Given this list of marker genes IMPG1, CFAP410, TTLL5, CABP4, GNB3, RD3, CACNA1F, GDF6, TOPORS, PDE6H, TULP1, IFT140, ATF6, LRAT, IFT172, KIZ, PDE6A, PRPF3, RGR, MFRP, USH2A, AGBL5, PEX12, TUB, DHX38, GRM6, RP1L1, MT-ATP6, NUP62, CNGB3, RP2, PRPH2, BBS2 (NCBI Gene Id 583), IDH3B, ARHGEF18, CNGA3, CC2D2A, KIAA1549, MAK, MERTK, REEP6, CNGB1, RPGR, OPN1SW, PRPF8, ARL2BP, RPE65, RS1, ADAR, RPGRIP1, ARL3, POMGNT1, ADAM9, PDE6C, RAB28, SNRNP200, NRL, PDE6G (NCBI Gene Id 5148), IDH3A, UNC119, BBS1, RP1, SLC24A1, PRPF31, OFD1, NYX, GRK1, PRPF6, IMPG2, IFT88, GNAT1, PITPNM3, IQCB1 (NCBI Gene Id 9657), KCNJ13, FSCN2, RBP3, CLRN1, CA4, FOXC1, CRX, ZNF408, ROM1, PRPF4, RP9, GUCA1A, SEMA4A, RDH5, FAM161A, PDE6B, CDHR1, PAX6, SLC7A14, PRCD, LRIT3, AHR (NCBI Gene Id 196), CACNA2D4, SAG, BEST1, RAX2, TTC8, DRAM2, GNAT2, NMNAT1, TRPM1, ALG3, USP45, ABCA4, MCOLN1, CYP4V2 (NCBI Gene Id 64587), ARL6, CFAP418, GUCY2D, TUBB4B, RIMS1, CNGA1, NEK2, AIPL1, RLBP1, TLCD3B, GUCA1B (guanylate cyclase activator 1B), ZNF513, TRIM44, PCARE, NR2E3, CRB1, ACOX1, IDS, NUP54, LCA5, IMPDH1 (inosine monophosphate dehydrogenase 1), OPN1LW, DHDDS, CEP290 (NCBI Gene Id 9707), SPATA7, SCAPER, GPR179, AHI1, OPN1MW, RHO, EYS, PPT1, HGSNAT, POC1B, CERKL, PROM1, KIF3B, RDH12, LARGE1, KLHL7, PCYT1A, here is a description of the gene set: Human Gene Set: HP_ABNORMAL_FULL_FIELD_ELECTRORETINOGRAM species: Homo sapiens Abnormal full-field electroretinogram